Given this list of marker genes Sh3glb2, Vim, Gsn, Gas2, Mapt, Add1, Casp8, Casp7, Casp3, Casp6, here is a description of the gene set: Reactome Pathway: Caspase-mediated cleavage of cytoskeletal proteins part of: Apoptotic cleavage of cellular proteins species: Mus musculus This event has been computationally inferred from an event that has been demonstrated in another species.<p>The inference is based on the homology mapping from PANTHER. Briefly, reactions for which all involved PhysicalEntities (in input, output and catalyst) have a mapped orthologue/paralogue (for complexes at least 75% of components must have a mapping) are inferred to the other species. electronically inferred by orthology from the curated human pathway